The following is a description of a gene set: species: Homo sapiens Polymicrogyria that affects all or some of both cerebral hemispheres. Bilateral polymicrogyria Human Gene Set: HP_BILATERAL_POLYMICROGYRIA, and this is the list of marker genes: SIN3A, MYCN, PI4KA, SRPX2, ADGRG1